The following is a description of a gene set: Human Gene Set: GSE37532_VISCERAL_ADIPOSE_TISSUE_VS_LN_DERIVED_TCONV_CD4_TCELL_DN from publication Cipolletta D, Feuerer M, Li A, Kamei N, Lee J, Shoelson SE, Benoist C, Mathis D (PMID 22722857) Genes down-regulated in T conv from aged mice: visceral adipose tissue versus lymph node. species: Homo sapiens We identified Pparg as a major orchestrator of the phenotype of adipose-tissue resident regulatory T cells (VAT Tregs). To establish the role of Pparg in shaping the VAT Tregs gene profile and cell dynamics, Tregs from lymph nodes and visceral adipose tissue of mice sufficient and deficient of Pparg expression in Tregs were double sorted for microarray analysis., and this is the list of marker genes: CSN1S2AP, GPR12 (NCBI Gene Id 283535), SLC22A3, KCNMA1, SYN2, S100A16, DMD, ANKK1 (ankyrin repeat and kinase domain containing 1), SNORA74A, KRT9, MIR150, LRRC2, SLCO5A1, PELO, SLC22A14, LRRC4, RTL5, STAR (NCBI Gene Id 6770), SYTL5, C8A, KRTAP5-2, PCSK5, ADGRG7, SLC6A13, ERICH5, R3HDML, RASAL2, MOBP, AQP2, GRPR, CRYGS, TCAM1P, ERFE, AGBL2, PTPN3 (protein tyrosine phosphatase non-receptor type 3), TNNC1, FLRT3, GAP43, SYT8, TNFRSF21, MEGF11, SLC25A29, ELOVL3, NKAIN3, SPATA31F3, ACTRT1, FABP9, SLC36A2, ZDHHC11, SNHG1, MESP2, KCNC4, ST6GAL2, MMP10, HYI (hydroxypyruvate isomerase (putative)), WT1-AS, SRPX2, NAA11, P2RX3, MEGF8, SLC5A11, PLA2G1B, PCDH15, AQP4, DRGX, NPTX1, RTP3, SLC35G3 (solute carrier family 35 member G3), FRMPD3, STAB2, STARD13, ALPK2, RSPO2, KLHL13, MARCHF10, PRM1, IGFN1, CLDN4, KCNAB1, SLC17A2, TDRD1, DTNA, NMS, NXPH2, GPM6A, GLP2R, GPHA2, ADGRB1, ADH4, SNORA61, SDR16C6P, KRTAP6-2, SLITRK5, LGR4, REP15, STBD1, IL31RA, SNORA73B, AVIL, HPD, USP17L5, ESX1 (ESX homeobox 1), SLAMF8, TSHZ2, CMTM5, ADAM28, NOX3, MIR23B, MRGPRX1, ANKRD42